Given this list of marker genes Tfb1m, Dimt1, Tfb2m, Mettl5, Zcchc4, here is a description of the gene set: Mouse Gene Set: GOMF_RRNA_ADENINE_METHYLTRANSFERASE_ACTIVITY Catalysis of the reaction: S-adenosyl-L-methionine + rRNA = S-adenosyl-L-homocysteine + rRNA containing methyladenine. species: Mus musculus